The following is a description of a gene set: Combining with a C-X-C chemokine and transmitting the signal from one side of the membrane to the other to initiate a change in cell activity. A C-X-C chemokine has a single amino acid between the first two cysteines of the characteristic four cysteine motif. studied in species Mus musculus Mouse Gene Set: GOMF_C_X_C_CHEMOKINE_RECEPTOR_ACTIVITY, and this is the list of marker genes: Cxcr6, Gpr35, Cxcr3, Cxcr4, Ackr3, Cxcr5, Cxcr1, Cxcr2